The following is a description of a gene set: Human Gene Set: DAZARD_UV_RESPONSE_CLUSTER_G4 Cluster G4: genes increasingly up-regulated in NHEK cells (normal keratinocyte) after 12 h time point after UV-B irradiation. To gain insight into the transformation of epidermal cells into squamous carcinoma cells (SCC), we compared the response to ultraviolet B radiation (UVB) of normal human epidermal keratinocytes (NHEK) versus their transformed counterpart, SCC, using biological and molecular profiling. DNA microarray analyses (Affymetrix), approximately genes) indicated that the major group of upregulated genes in keratinocytes fall into three categories: (i). antiapoptotic and cell survival factors, including chemokines of the CXC/CC subfamilies (e.g. IL-8, GRO-1, -2, -3, SCYA20), growth factors (e.g. HB-EGF, CTGF, INSL-4), and proinflammatory mediators (e.g. COX-2, S100A9), (ii). DNA repair-related genes (e.g. GADD45, ERCC, BTG-1, Histones), and (iii). ECM proteases (MMP-1, -10). The major downregulated genes are DeltaNp63 and PUMILIO, two potential markers for the maintenance of keratinocyte stem cells. NHEK were found to be more resistant than SCC to UVB-induced apoptosis and this resistance was mainly because of the protection from cell death by secreted survival factors, since it can be transferred from NHEK to SCC cultures by the conditioned medium. Whereas the response of keratinocytes to UVB involved regulation of key checkpoint genes (p53, MDM2, p21(Cip1), DeltaNp63), as well as antiapoptotic and DNA repair-related genes - no or little regulation of these genes was observed in SCC. The effect of UVB on NHEK and SCC resulted in upregulation of 251 and genes, respectively, and downregulation of genes in NHEK and genes in SCC. To further analyse these changes, we used a novel unsupervised coupled two-way clustering method that allowed the identification of groups of genes that clearly partitioned keratinocytes from SCC, including a group of genes whose constitutive expression levels were similar before UVB. This allowed the identification of discriminating genes not otherwise revealed by simple static comparison in the absence of UVB irradiation. The implication of the changes in gene profile in keratinocytes for epithelial cancer is discussed. studied in species Homo sapiens from publication Dazard JE, Gal H, Amariglio N, Rechavi G, Domany E, Givol D (PMID 12771951), and this is the list of marker genes: H1-10, APRT, PRSS3, PFN1, MMP10, CDKN1C, TUBB3, SULT2B1, TUBB4A, TUBB4B, PPP2R1A, SOX15, H2AC18, ZFP36, XBP1, GADD45B, ARHGDIA, KRT34, CAPNS1, DUSP1